The following is a description of a gene set: Human Gene Set: AP1_Q2 Genes having at least one occurrence of the motif RSTGACTNANW in the regions spanning 4 kb centered on their transcription starting sites. This matches the JUN transcription factor binding site V$AP1_Q2 (v7.4 TRANSFAC). species: Homo sapiens, and this is the list of marker genes: CAMKK1, SGTB, TENM3-AS1, CDKN1B, FGF11, NRXN2, KCNN4, HPSE2, NCDN, KY, KLHL40 (NCBI Gene Id 131377), C1orf43, DKK2 (dickkopf WNT signaling pathway inhibitor 2), RELL2, FAM184A, MAP1A, COL27A1, EPHA2, PDAP1, STOML2, IL23A, CLC, DTX2 (deltex E3 ubiquitin ligase 2), VDR, CRYGS, PAK6, DUSP13B, MINK1, CCDC50, FLI1, BLMH, SIX4, PTPRR, PRELID3B, ZIC4, S100A10, DSTN, CILK1, CREM, SLC38A3, ORAI1, RNF144B, PORCN (NCBI Gene Id 65017), TOB1, HS3ST2, FHL3, PAK5, PIM2 (Pim-2 proto-oncogene, serine/threonine kinase), ACTR1A, LPP, IGFBP6, HSPB7, SDCBP, AKT1S1, DCTN2, MAPRE3, WDFY3, LTBP3, NLRC4, FBXW11, CAPNS1, CIZ1, PAPPA, SLC9A5, DCDC1, FOS, RAP1GAP2, GOLGA4, NECAB3, DDX17, STAT5B, FLNC, MFGE8, ROM1, DNM1, EIF4G1, SLC9A9, LYVE1, RIN1, ARRDC4, PPP2CA, NPY, EML3, ZNFX1, APOBEC1, NRIP3, IL9 (interleukin 9), MAGED1, PITPNC1, SMAP2, ZNF516-DT, MPRIP, ELAVL2, SYTL1, SMARCA2, CRYBA2 (crystallin beta A2), SH3RF2, KLHL1, CCDC65, WDFY3-AS2 (NCBI Gene Id 731216), NEFH, CLUH, NDP, MAP4K5, GNAI1, RAB22A, MMP7, PKN3, LMNA, RP1L1, GAB2, AK5, ST18, CNTF, UBQLN1, FARP1, LAMB3, CA7, SSH2, CYP24A1, SRPK2, DCHS1, HOXA11, ZIC1, UCN2, KCNH6, EPB41L1, PRDM1, HDAC3, UBE2C, TCF12, TEX19, PSMD11, CASK, TGFBR2, NRAS (NCBI Gene Id 4893), VIM, SFN, FGF12, PLPBP, ZNF362, CLVS1, MDFI, UBE3A, TRPV3, XPOT, RAD23B (NCBI Gene Id 5887), HOXA13, GPR150, EVI2B, GJB3, TMEM156, ID1, KLHL41, KDM3A, ST8SIA5, TRIM8, RAPGEF6, DCN, USP13 (NCBI Gene Id 8975), RAB37, TUBA1C, XIRP1, AP2A2, ADORA2A, PRKACA, IL1RN, ASS1, BAZ2A (NCBI Gene Id 23525), LRP1B, GGN, TBC1D10B, TXN, CYTOR, PLAC1, CD244, SPTA1, C1QTNF8, GAPDH, ZNF385B, SLC16A6, TMCC1, CCL22, SCRN1, PDGFRB, ELK3, NLN, FAM178B, NHS, PCDH9, POLR3E, OMG, IGSF22, ETV5, JMJD1C, MEIS2, ZBTB2, HOXA3, MAP2, CMAS, CORO1C, LAMC2 (NCBI Gene Id 3918), PLCD1 (phospholipase C delta 1), PLEKHH3, MAPK3, MMP9, PLBD2, CA9, S100A5, ATXN7L2, PAX9, CACUL1, SLC31A1, VEGFD, FAP, PTPRH, STK40, EFNA1, RTN3, ZNF771, SHC3, ANKRD28, SNCB, CLSTN3, MAP4, SLC25A51 (solute carrier family 25 member 51), KCNH2, GADD45A, MMP19, IRAK1, SLC35E4, RNF128, IL10, TBC1D17, TENT5A, NTRK2, AXIN2, LCTL (lactase like), LAPTM5, CALM3, ROCK2, ANXA7 (annexin A7), UCHL3, STX17, BUD31, USP2, GSN, RGS8, BAIAP2, USP3 (NCBI Gene Id 9960), ZPBP2, SUFU, PTPRN, KCNK10, APOBR, CYP11A1, PIANP (PILR alpha associated neural protein), PRDM13, SCOC, MYBPH, PSMA3, IL6, BNC2, PPP1R9B, LAMC1